The following is a description of a gene set: from publication Chen Y, Wang X (PMID 31504780) Human Gene Set: MIR4769_3P Genes predicted to be targets of miRBase v22 microRNA hsa-miR-4769-3p in miRDB v6.0 with MirTarget v4 prediction scores > 80 (high confidence targets). species: Homo sapiens, and this is the list of marker genes: PGK1, CGREF1, SMIM14, NIPBL, SIGLEC6, LPIN1, VAPA, WIPI2, CNNM1, ZNF254, SASS6, NET1, FXR1 (NCBI Gene Id 8087), GGACT (gamma-glutamylamine cyclotransferase), RBM15, GLRB, BNC2, DAB1, HACE1, NFKBIE, ATRX, DTNA, ACVR2B, B3GNT3, CAPZA1, RCN1, CSTF3, ZNF423, SYT9, MCTS1, SVOP, PLAAT1, IP6K3, BCL6B, WDR3, KIAA0408, GRM5, ZNF843, GUCY1A2, SHOC2, MBD5, MAPK8, RAB6A, PTEN, TMEM254, ADGRL3, MTCL3, RADIL, PTAR1, RBMY1F, ERBIN, ZNF135, PRIM1, YY1, HMG20A, PPM1H, ZNF608, CCDC6, GRID2 (NCBI Gene Id 2895), CCDC141, C2orf72, PAK2, COMMD8, PCBD1, SUB1, HDAC2, SEC22C, ZNF23, DUSP12, CIPC (NCBI Gene Id 85457), ATF1, CSNK1G1, MAP3K13, HSF2, MARCHF5, CLIC4, YTHDF1, TMEM106B, WAPL, DGCR2, BPTF, RASSF3, TSC1 (NCBI Gene Id 7248), ITLN1, KHNYN, KCNIP3, AKTIP, FAM131A, TMSB15B, BCL6, TM9SF2, ESYT3, DMD, NFAT5, PPARA, CDC26, KALRN, CPNE4, SEMA6A, ADAM9, RHBDF2, GABRA1, FAM240A, HOOK3, ANO5, TRAPPC6B, POU4F2, PILRB, EML4